The following is a description of a gene set: Mouse Gene Set: GOBP_POSITIVE_REGULATION_OF_MITOCHONDRIAL_ATP_SYNTHESIS_COUPLED_ELECTRON_TRANSPORT Any process that activates or increases the frequency, rate or extent of mitochondrial ATP synthesis coupled electron transport. studied in species Mus musculus, and this is the list of marker genes: Ccnb1-ps, Ccnb1, Chchd2-ps, Cdk1, Chchd2